The following is a description of a gene set: To examine the impact of tumors on the immune system, we compared global gene expression profiles of peripheral blood T cells from previously untreated patients with B cell chronic lymphocytic leukemia (CLL) with those from age-matched healthy donors. Although the cells analyzed were not part of the malignant clone, analysis revealed differentially expressed genes, mainly involved in cell differentiation in CD4 cells and defects in cytoskeleton formation, vesicle trafficking, and cytotoxicity in CD8 cells of the CLL patients. In coculture experiments using CLL cells and T cells from healthy allogeneic donors, similar defects developed in both CD4 and CD8 cells. These changes were induced only with direct contact and were not cytokine mediated. Identification of the specific pathways perturbed in the T cells of cancer-bearing patients will allow us to assess steps to repair these defects, which will likely be required to enhance antitumor immunity. Gene expression profiling was performed to determine whether CLL cells induce changes in T cells in patients with CLL. Human Gene Set: GSE8835_HEALTHY_VS_CLL_CD4_TCELL_DN from publication Görgün G, Holderried TA, Zahrieh D, Neuberg D, Gribben JG (PMID 15965501) Genes down-regulated in CD4 T cells: healthy versus CLL (chronic lymphocytic leukemia)l. studied in species Homo sapiens, and this is the list of marker genes: FBXO16, PLXDC2 (NCBI Gene Id 84898), SLC25A10, SCARF2, MBOAT1, CAMK2G, TIAM2, NUP37, LGI3, NMUR2, EMILIN1, TASOR, AP2A2, C11orf91, ZSWIM1, COL13A1, NUP42, TSSK2, SLC17A5, MDP1, SLC13A3, RMDN1 (NCBI Gene Id 51115), CA14, EFNB1, GABRA5, SLC4A10, SMG9, LMLN, MED18, BMERB1, LBP, HFE, CRHBP, KIAA0930, OPRM1, SPART, ZNF169, NALCN, SLITRK1, HACL1, CELSR3 (NCBI Gene Id 1951), UROC1, PTPRG, MCUB, SERINC5, OBP2B, TMEM89, CRTC3, ZSCAN20, SNHG17, CLDN4, ZNF770, NEIL1, CA5B, RIBC2, TBC1D8, GABRA6, NRG1, GLMN, MYBPC3 (myosin binding protein C3), BIN3, CSF1R, REEP4, RELN, SRSF12, FBXL2, UBR5, VWF, DNAH7, KCNJ5, GMNN, DNAAF6 (dynein axonemal assembly factor 6), CCNB2, PTGR1, BBS9, RBM44, IDH1, BLM, PNN, SLC22A25, BEX4, FOXD1, PCDH11X, RAD51AP1, RALYL, MAS1, ZFYVE28, CNGA4, SUGCT, ZNF475, DAO, KRT33A, IGF2-AS, CCT5, RCBTB1, TMEM139, HOXB5, STYXL1, PTGDR2, CDCA4, GPR85, STEAP2, NUDCD2, KCNK2, PITPNM2, C12orf71, HELLS, MTMR3, ARL5A, INCENP, FGR, C12orf75, NTM, URM1, CATSPERZ, TREH, BMX, CYP7B1, SEPTIN1, PSORS1C2, ITGA9, ZBTB26, C1orf21, ELN, LINGO3, DDHD1, CIITA, KNL1, NBAS, CSRNP3, DBF4, PGBD1, MAGEB5, MMS22L, MMD, GLIPR1L2, DEPTOR, CLEC2L, MEDAG, TBC1D16 (NCBI Gene Id 54493), KRTAP4-3, DIP2C (disco interacting protein 2 homolog C), ADAM28, HTR7, OC90, CACNA1S, GDAP1L1, GPR171, TMCO2, ELOVL6, POGLUT2, ACTL7A, PRG4, LAX1 (NCBI Gene Id 54900), ZBTB22, ZNF76, KDM4B, PLA2G10, F7, CCDC191, EPHB2, TMEM269, KCNS3, MAPK13, OOEP, BUB1, RTN4RL1, POU1F1, TMEM91, USP19, ANK1, LRRC23, AMPH, RFC1, EPB42, FCER2, GBF1, ALDH5A1, POTEH, A4GALT, ZNF518B, BEST1, TRIL, EML1, DDIT4L, MYO18B, CBR3, B3GAT1, ARMC12, HOXC6, FABP7, BBS5, FFAR2, ADGRD1, HDAC6, TCF15, EXTL1, TSNAXIP1, ARVCF, SPON1